Given this list of marker genes TGFBR3, ACVR2A, INHA, INHBA, here is a description of the gene set: This subpathway describes the regulation of activin signaling by TGFBR3. TGFBR3 binds with Inhibin A, which is also a ligand for TGFBR3 and inhibits activin/BMP signaling by binding competititively to ACVR2A receptor and BMPRII. part of: Signaling by TGFBR3 studied in species Homo sapiens Reactome Pathway: TGFBR3 regulates activin signaling